The following is a description of a gene set: studied in species Mus musculus Mouse Gene Set: GOBP_DNA_REPLICATION_CHECKPOINT_SIGNALING A signal transduction process that contributes to a DNA replication checkpoint, that prevents the initiation of nuclear division until DNA replication is complete, thereby ensuring that progeny inherit a full complement of the genome., and this is the list of marker genes: Timeless, Nae1, Rad9a, Orc1, Rad9b, Dna2, Mdc1, Hus1b, Tipin, Cdc6, Ticrr, Donson, Topbp1, Clspn, Zfp830, Rad17, Cdt1, Hus1